Given this list of marker genes Lgsn, Nr1h4, Bcl2, Bax, Abcc1, Asl, Glul, here is a description of the gene set: Mouse Gene Set: GOBP_INTRACELLULAR_NITROGEN_HOMEOSTASIS studied in species Mus musculus A homeostatic process involved in the maintenance of a steady state level of nitrogen within a cell.